The following is a description of a gene set: Any process that modulates the frequency, rate or extent of lymphocyte activation. species: Homo sapiens Human Gene Set: GOBP_REGULATION_OF_LYMPHOCYTE_ACTIVATION, and this is the list of marker genes: IL1B, VAV3, TNFSF8, CLEC4G, IL20RB, IL27RA, BTK, SELENOK, RHOH, KLRC3, SOS1, HLA-DMB (major histocompatibility complex, class II, DM beta), XRCC6, KMT5C, ARID1A, IGFBP2, MLH1, SH3RF1, DUSP22, PYCARD, PTPN22 (NCBI Gene Id 5779), IRF1, IFNL1, CAV1, FGF10, KAT5 (NCBI Gene Id 10524), ZNHIT1, TBX21, PMS2, SMARCC2, SLC46A2, DUSP3, CDKN2A, MAD2L2, VCAM1, FOXP3, BID, FOXN1, PRLR, CD1D, FLOT2, SMARCE1, IL4R, EXOSC3, AHR, NCK2, IL13, CD40, HLA-DRB4, CD274, PPP3CA, KITLG, DROSHA, IDO1, KAT2A, PCK1, IL5, ZP4, TBC1D10C, ATAD5, RPS3, SOX4, CD70, ACTB, SOX13, SIRPA, PRKAA1, BCL10, LCK, BTN2A2, ZEB1, PARP3, SOX12, BTLA, CGAS, SMARCC1, RAC2, LST1, RHOA, IFNG, METTL3, CD209, NDFIP1, EFNB1, FCRL3, THY1, AP3B1, VAV1, HAVCR2, WNT3A, DUSP10, B2M, TNFAIP8L2, LMO1, IGF1, HLA-DPA1, CD37, KLRK1 (NCBI Gene Id 22914), VSIR, MARCHF7, TIGIT, GAL, SIT1, TAC1, MIR27A, BMI1, BMP4, PRDX2 (NCBI Gene Id 7001), KLRC4-KLRK1, LOXL3, HLA-DQA1, AGER, NKAP, SLC7A1, PIK3CD (phosphatidylinositol-4,5-bisphosphate 3-kinase catalytic subunit delta), IL23R, CYLD, MMP14, SHLD3, MDK, NOD2, ZFP36L2, LGALS9C, AKIRIN2, IL2, ITCH, HHLA2, SRC, TICAM1, HMGB1, IKZF3, KCNK18, PCID2, IRS2, PRKCQ, SHLD1, HLA-E, BRD4, SAMSN1, SCRIB, PRELID1, ADORA2A, ZBTB16, INHA, PRKCZ, IL21, RC3H2, LGALS1, CD5, DDRGK1, CR1, CD22, VTCN1, IL1RL2, GPR65, HFE, MEF2C, MAPK8IP1, RIPK2, TNFRSF13C, TNFAIP3 (NCBI Gene Id 7128, TNF alpha induced protein 3), TSPAN32 (tetraspanin 32), NFKBID, TYRO3, CCL5, TGFBR2, PBRM1, IL12A, PLA2G5, GPNMB, CCDC88B, VSIG4, NSD2, SMARCD1, STAT6, CD320, BRD2, WNT10B (NCBI Gene Id 82499), FLT3LG, HLA-DMA, FYN, LEF1, DTX1, LILRB4, STAT5B, CD81, GLMN, TGFB1, TYROBP, CTSG, PLA2G2F, SPTA1, FADD, TWSG1, FANCD2, SHH, CLEC12A, SYK, CHRNB2, AKT1, SPI1, MERTK, CAMK4, TLR4, PIBF1, TNFRSF21, CCL2, BLOC1S3, ASCL2, RPL13A, SIRPB1, CD27, MAP3K8, ATM, CLNK, MNDA, RHBDD3, NFAM1, ARID1B, MIR181C, ACTL6A (actin like 6A), ZNF335, RNF41, SOS2 (NCBI Gene Id 96829), GPR183, ZNF683, SLAMF1 (NCBI Gene Id 6504), JAK2, IL6, BAD, IL18, CSK, TNFSF11, HMCES, DNAJA3, CD74, MZB1, TMEM131L, FCHO1, LGALS9B, HLA-DRB5, BATF, CD69, KLRC1, LAPTM5, LILRB2, APLF, RASAL3, PSG9, LEP, RAG1, TNFRSF4, MYD88, IL15, IL23A, PGLYRP2, CLPTM1, OPA1 (NCBI Gene Id 4976), INPP5D, ZBTB7B, RUNX3, ICOS, BRD7, CD276, SLAMF8, HLA-A, NFKBIZ, PPP2R3C, BRAF, GAS6, CLC, TNFSF13, TNFSF18, LAT, PAG1, MIR130A, RIPK3, HMGB3, CD38, ADAM8, SHLD2, SPINK5, DHPS, XBP1, ACTL6B, HLA-DOB, ABL1, PNP, CCL21, YWHAG, TESPA1, ABL2, CYRIB, SOD1, BANK1, DLG1, INHBA, PGLYRP3, JUNB, SLC39A10, SOCS5, IL12B, CD47, HLA-DOA, CD2, NLRP3, CYP26B1, BST1, SMAD7, CD24, FOXO3, EFNB2, TRAF6, CD160, TLR9, KLHL25 (kelch like family member 25), LGALS3 (galectin 3), SMARCA4, HLA-DRA, DPP4, RAG2, CARD11, CD83, ZBTB1, TP53BP1, ADA, HLA-DPB1, HLA-G, EPO, ZAP70, SMARCD2, BCL2, LRRC32, SHB, KMT5B, IL15RA, FOXJ1, IL2RG, SOX11, ZC3H8, EBI3, MIF, VNN1, LGALS9, SLC15A4, TCF3, CTNNB1 (catenin beta 1), ID2, CD46, TNFSF4, CLCF1, MICA, RC3H1, TYK2, TNFRSF9, TNFRSF13B, PELI1, IL10, HSPD1, CD19 (NCBI Gene Id 930), CDKN1A, UFL1, RIF1, IL4, PGLYRP1, LYN, NRARP, NFATC2, HES1, ZMIZ1, KLRC2 (killer cell lectin like receptor C2), EPHB2, MALT1, PHF10 (NCBI Gene Id 55274), TOX, HLA-DRB3, CRTAM, EXOSC6, NEDD9, PLA2G2A, HLA-DQB2, CD3E, ARID2, KLRD1, TNFRSF14, PIK3R6, THEMIS2, SIRPG, CCR7, EP300, LILRB1, SMARCD3, NCK1, GLI2, MIR17HG, NCKAP1L, TCF7, AIF1, PTPRC, TIRAP, IL1A, ITPKB, KLHL22, GLI3, TARM1, SH3KBP1, LAX1, CD28, GNRH1, PRKAR1A (NCBI Gene Id 5573), FCGR3A, SMARCA2, HLX, BCL6, YES1, DAPL1, LAG3 (NCBI Gene Id 3902), GPAM, TNFSF14, LGALS8, CASP3, RUNX1, DOCK8, CLEC7A, SPN, ARG1, PLA2G2D, SOCS6, EFNB3, PAXIP1, BLOC1S6, RARA, PKN1, CD6, CBLB, FCGR2B, ICOSLG, IL7R, ZC3H12A, HSPH1, MTOR, MSH2, IL4I1, SART1, IRF4, CLECL1P, IFNA2, SMARCB1, TACR1, RASSF5, SLC4A2, ZP3, CD80, IL6ST, PTPN6 (NCBI Gene Id 5777), CORO1A, IL12RB1, IGF2, CD86, ILDR2, SDC4 (syndecan 4), XCL1, FGL2, HLA-DRB1, FGL1, CD4, TREX1, AMBRA1, SFRP1, SASH3, MIR185, SFTPD, ERBB2, TMIGD2, CD300A, ZFP36L1, PTPN2, PRDM1, STAT5A, CD40LG, HLA-DQB1, IL7, PAWR, JAK3, TFRC, PDPK1, RASGRP1, PDCD1, PRKDC, FGR, CD55, ANXA1, DCAF15, CTLA4, RIPOR2, IL2RA, BTNL2, TNFRSF1B, PRNP, MAD1L1, SCGB1A1, AXL, CCR2, CCL19, CEBPB (CCAAT enhancer binding protein beta), FBXO7, IL27, NR5A2, TNIP2, AP3D1, ARG2, IFNB1, PDCD1LG2, MIR30B, CBFB, DLG5, SOCS1, SUPT6H, TNFSF13B, FBXO38, HLA-DQA2, IHH, GATA3, IL36B, FANCA, EGR3, MIR21, TNFSF9, PTPN11, MPL